The following is a description of a gene set: Nucleotide biosynthesis Human Gene Set: REACTOME_NUCLEOTIDE_BIOSYNTHESIS studied in species Homo sapiens, and this is the list of marker genes: ATIC (5-aminoimidazole-4-carboxamide ribonucleotide formyltransferase/IMP cyclohydrolase), UMPS, DHODH, IMPDH1, ADSL, PPAT, ADSS1, IMPDH2, CAD, PFAS, ADSS2, GMPS (guanine monophosphate synthase), GART, PAICS